Given this list of marker genes Bsg, Slc16a3, Slc16a8, here is a description of the gene set: electronically inferred by orthology from the curated human pathway Reactome Pathway: Proton-coupled monocarboxylate transport part of: SLC-mediated transport of organic anions species: Mus musculus This event has been computationally inferred from an event that has been demonstrated in another species.<p>The inference is based on the homology mapping from PANTHER. Briefly, reactions for which all involved PhysicalEntities (in input, output and catalyst) have a mapped orthologue/paralogue (for complexes at least 75% of components must have a mapping) are inferred to the other species.